The following is a description of a gene set: species: Homo sapiens This pathway groups reactions mediated by 2-OG (2-oxoglutarate)-dependent oxygenases that target proline, lysine, asparagine, arginine, aspartate, and histidine residues of diverse proteins, with effects that potentially modulate transcription and translation (Herr & Hausinger 2018; Markolovic et al. 2015; Stoehr et al. 2016; Zurlo et al. 2016).<p>The roles of members of this enzyme family in collagen assembly are annotated separately in pathway "Collagen biosynthesis and modifying enzymes". Reactome Pathway: Protein hydroxylation part of: Gamma carboxylation, hypusinylation, hydroxylation, and arylsulfatase activation, and this is the list of marker genes: RCCD1, JMJD7, ETF1, RWDD1, RPL27A (NCBI Gene Id 84736), KDM8, RPS23, F9 (NCBI Gene Id 14071), RIOX1, DRG2, RPS6, U2AF2, RPL8, DRG1, JMJD6, RIOX2, ZC3H15, JMJD4, ASPH, OGFOD1